Given this list of marker genes ADI1 (acireductone dioxygenase 1), POLL, KMO, TIRAP, SLC35D2, UNK, MICU2, CYB561D1, SAMD8, CASP2, FLT4, EP400, HDAC5, ARL8B, OSGIN2, GPR83, RANBP10, SPSB2, SESN2, FCMR, CCDC8, TTC17, AAGAB, RNF181, RMDN3, CYP11A1, OTUB1, CNR1, PNPLA7 (NCBI Gene Id 92716), TASOR2, SNAPC3, REPIN1, LMBR1L, AMZ2, PPARG, MOCS2, POLDIP3, MED13, ACCSL, PPARGC1A, HCRTR1, MOSMO, DNAJC5, ABHD13, NEMP2, SPA17, CLIC1, FAIM, MED10, SHKBP1 (NCBI Gene Id 92799), TRAPPC5, RMDN1, ARID5A, RAB22A, CCNL2 (NCBI Gene Id 9613), PKN1, GPR108, RIPK1, KLHL38, ZFYVE26, S100A10, MRPL49, L3MBTL2, DMAC2, USP8, EFHD2, PTPN2, BLOC1S2, VCAN, ZFAND5, YTHDF1, ATP6V1B1, RNF215 (NCBI Gene Id 200312), RGS14, NAGLU, PLIN3, PLOD3, MIR598, YKT6, MAN2A1, ANKRD16, CLEC2D, SCO1, SERINC3 (NCBI Gene Id 10955), ADGRG5, RNF167, PHOSPHO2, NBAS, TNFRSF1A, VRK3, IQSEC2, TTYH2 (tweety family member 2), BICRA, RAD51D, CSF2RBP1, PPP6R1, FCF1, TLR8, HCK, MCM6, TFEB, SFRP2, SUDS3, SH2D6, CCL8, PSAP, MAP4K3, VWA3B, MDFIC, TXNDC9, MGLL, SARAF, DYRK1A, CYP8B1, CHRNA5, CLEC12A, ARHGAP28, ARMC7, SIK3, UBTD1, TAOK3, PTCD2, FOLH1, ANPEP, PHLDA3 (pleckstrin homology like domain family A member 3), ANKRD17, MED20, PKP4, ANKIB1, ASB18, FAM170A, FBRSL1 (fibrosin like 1), STK4, MSRB2, GTDC1, MVP, RDH5, GPR33, TAF12, IL3RA, SUN2, SLC2A6, BACH1, BAIAP2, UBD, DENND2A, POMP, INSL6, ZFPL1, DFFB, POR, TBXT, NEK9, STAT6, APOE, ABHD12, SCNM1, NEIL2, AMN1, FBLN5, VCPIP1, KIF4B, IL23R, SERPINB8, SLC25A28, here is a description of the gene set: Genes down-regulated in hematopoietic stem cells versus multipotent progenitors. Human Gene Set: GSE37301_HEMATOPOIETIC_STEM_CELL_VS_MULTIPOTENT_PROGENITOR_DN from publication Ramirez K, Chandler KJ, Spaulding C, Zandi S, Sigvardsson M, Graves BJ, Kee BL (PMID 22608498) Expression profiling of Rag2-deficient Ets1++ and Rag2-deficient Ets1-- mature NK cells and WT bone marrow progenitors, WT T cells, and WT Pro B cells species: Homo sapiens